Given this list of marker genes Rock2, Lamtor1, Meak7, Akt1, Gpr137b, here is a description of the gene set: Any process that modulates the frequency, rate or extent of protein localization to lysosome. species: Mus musculus Mouse Gene Set: GOBP_REGULATION_OF_PROTEIN_LOCALIZATION_TO_LYSOSOME